The following is a description of a gene set: from publication Ochiai K, Maienschein-Cline M, Simonetti G, Chen J, Rosenthal R, Brink R, Chong AS, Klein U, Dinner AR, Singh H, Sciammas R (PMID 23684984) Human Gene Set: GSE46606_IRF4_KO_VS_WT_CD40L_IL2_IL5_3DAY_STIMULATED_BCELL_DN Genes down-regulated in CD40L and IL-2 IL-4 IL-5 stimulated at day 3 B cell IRF4-KO versus CD40L and IL-2 IL-4 IL-5 stimulated at day 3 B cell wildtype. studied in species Homo sapiens Temporal analysis of B cell activation in vitro using CD40L and IL-2/4/5 cytokines in wild type Irf4+/+ B cells or in mutant Irf4-/- B cells harboring a tet-inducible allele of Irf4. IRF4 expression was restored, or not, in the Irf4-/- background by culturing in the presence of low or high concentrations of doxycycline. The results provide insight in the role of IRF4 expression levels in coordinating different programs of B cell differentiation., and this is the list of marker genes: NUP214, SEC24C, NOL12, TLR4, BRWD3, HBB, ERP44, SGK3, CHMP2A, DHX38 (DEAH-box helicase 38), SDS, ARHGAP24, CNTRL, TNFRSF8, EEPD1, NCOA1, ZNF79, CHML, WAC-AS1, HACD4, RNF220, MSR1, RNF25, G2E3, EFNA4, OR52K3P (NCBI Gene Id 81256), MCUB, MCRIP1, SNHG10, GSG1, DDX39A, SLC22A18AS, DRG1, MSL2, SURF4, IKZF5, HCLS1, CYTH3, DCBLD1, TACC1, ILF3-DT, SPACA4, ING3, MAP3K7CL, PAQR6, RFC2, CD48, CENATAC, ZNF565, NSFL1C, NGF, MARK3, CREBBP, CAPN2, ADGRE3, WDR91, NOL9, PID1, CHD4, PSMA3-AS1, TAF1, IPO9, CPNE8, HAL, TFIP11, CHMP3, SAFB, ARAP3, KCNJ15, AHRR, MPP1, EMILIN1, CRTAM (NCBI Gene Id 56253), SFR1, SLC35B1, ZDHHC2, IFT88, CDK20, CDC26, FGD6 (FYVE, RhoGEF and PH domain containing 6), LPAR6, DOK2, TMEM216, UPF1, PIGM, HMGN2, GMEB1, ZSCAN32, PRPF38A, SMCHD1, TRAV8-3, ARHGAP27, CRELD2 (NCBI Gene Id 79174), GTF2IRD2, SGF29, ATP10A, CCDC88C, CHRAC1 (NCBI Gene Id 54108), ARIH2, CERS2, ZZEF1, SNRK, ASTE1, CLEC5A, ZNF587, CCDC112, PARVG, ZNF14, PADI4, NINJ2-AS1, STX6, VNN2, SCAMP2, HTR7P1, CRLF3, BST1, SDF2, PIK3R5, CYB561A3 (cytochrome b561 family member A3), SCAF11, ADAM28, C22orf39, GIGYF2, SNRNP27, AATK, ELOF1, TECPR1, CDKN1C, JAKMIP2, CHMP7, EIF4E3, LRRC37B, BOD1L2, RBP7, MED20, ZCCHC14, ZNF410, ATPAF1, RTL5, TNFSF8, MEF2C, LYN, ZNF555, RING1, RCBTB2, TESK2, CCDC59, TRMT5, VPS25, ITFG2, WDR53, HNRNPH3, UBE2E3, SEZ6L2, SLC35F6, GAS7, KPNA1, TMEM208, C12orf43, HSPBAP1, ANKRD49, TPD52L2, HPSE, ZNF322, AP1S2, PITHD1, KMT2C, NOSIP, MIR497HG, MED14OS, CAB39, REV3L, SMIM11, KXD1, CROCCP2, NEDD4, PLPBP, ATP6V0D1, INPP5A, RBM14, CLIP2, GPATCH3, GPR45, TM9SF1, CD36, CASP1, ZNF830, SETX, JDP2, FIRRM, GNA12, SNHG20, FCN1, SDSL, BLOC1S1